Given this list of marker genes CSF2RB, FGR, TOP2A, IRF8, RBM47, FCGR1A, XDH, VCL, E2F8, ATP2A3 (NCBI Gene Id 489), CDK6, CXCL9, CCR2, MGST1, CCDC50, TRIM34, RAPGEF5, DENND5B, SMPDL3B, KLRC3, CD80, DPY19L3, PIK3AP1, FIGNL1, ARAP1, CXCL10, MBNL1, IL1R2, CD300LF, ADGRE1 (NCBI Gene Id 2015), SLC43A1, SSH1, ARHGAP19, TIFA, PXN, PLK1, GRN, SKAP2, CFB, NCAPG2, ANXA2, TPX2, GEM, S100A9, MYO5A, EDEM1, GZMB, C3, TLN1, LY6S, AGO2, NOD1, LILRB4, PRRC2A (NCBI Gene Id 7916), POU2F2, PLXNB2, FCGR2B, HDC, CD83, UBE2J1, S1PR5, MKI67, SEMA7A, ASNS (asparagine synthetase (glutamine-hydrolyzing)), BHLHE41, RASSF4, KLRC2, H2BC3, SRGAP2, PDE8A, E2F1, GNS, CD274, STAT1, PRC1, FCGR3A, TTC7B, FZR1, NOTCH2, NUP210, NOTCH1, CFP (NCBI Gene Id 5200), IL18RAP, SLC15A3, C1orf54, NRP1, FGL2, GZMA, CYFIP2, TGFBI, GDA, FAM20B, BLVRB, NUAK2, TRIP13, NEB, KLRG1, DTL, SAMHD1, NSL1, LITAF, PHLPP2, OSBPL3, CAMP, NLRC5, H2AC15, KIF11, RAB31, S100A6, ECT2, CD68, ITPRID2, PTPN9, NF1, PREX1, CELSR1, SLPI, TBX21, BCL2L1, LTF, CENPE, CYP17A1, DNA2, CSF1R, PTAFR, PON3, CCNB2, SLC16A6, ANLN, TLR9, RNF216, GPR141, PRR11, PML, HMMR, FAM120A, CDC25C (cell division cycle 25C), MMP9, IL36G, SNX9, FPR1, ARHGAP26, CCNA2, CD44, RALGAPA2, ALOX5, SLC66A3 (NCBI Gene Id 130814), PYGL, RAP1GAP2, EAF2, PLCG2 (phospholipase C gamma 2), ANKRD55, CCL5, ELL2, SEC61G, TXN, FCER1G, ZBP1, CASP4, MXD1, ABHD4, ADAP1, WEE1, PFKFB3, LCN2, GAA, EOMES, YBX3, STIL, CCNF, AKT1, PIK3CG, TEP1 (telomerase associated protein 1), ZEB2, KIF15, KLRC1, here is a description of the gene set: Expression profiling of Rag2-deficient Ets1++ and Rag2-deficient Ets1-- mature NK cells and WT bone marrow progenitors, WT T cells, and WT Pro B cells studied in species Homo sapiens Human Gene Set: GSE37301_HEMATOPOIETIC_STEM_CELL_VS_CD4_TCELL_UP Genes up-regulated in hematopoietic stem cells versus CD4 T cells. from publication Ramirez K, Chandler KJ, Spaulding C, Zandi S, Sigvardsson M, Graves BJ, Kee BL (PMID 22608498)